The following is a description of a gene set: species: Mus musculus Any process that activates or increases the frequency, rate or extent of chromosome separation. Mouse Gene Set: GOBP_POSITIVE_REGULATION_OF_CHROMOSOME_SEPARATION, and this is the list of marker genes: Ncapg2, Smc2, Ncapd3, Numa1, Aurkb, Anapc5, Incenp, Cdc16, Ube2c, Mapk15 (NCBI Gene Id 332110), Anapc7, Cdc20, Ncaph, Cenpe, Anapc11, Smc4, Birc5, Cul3 (cullin 3), Prap1, Plscr1, Cdca8, Ska3, Cdc23, Mad1l1, Ncaph2, Mad2l1bp, Nsmce2, Rb1, Ska1, Ncapd2